The following is a description of a gene set: species: Homo sapiens Human Gene Set: GOMF_ARYLSULFATASE_ACTIVITY Catalysis of the reaction: a phenol sulfate + H2O = a phenol + sulfate., and this is the list of marker genes: ARSL (arylsulfatase L), STS, SULF1 (sulfatase 1), ARSF (NCBI Gene Id 416), ARSG, ARSI, ARSB, ARSA, SULF2, ARSK, ARSD, GALNS, ARSJ, ARSH